The following is a description of a gene set: NR1H2 and NR1H3-mediated signaling Human Gene Set: REACTOME_NR1H2_AND_NR1H3_MEDIATED_SIGNALING studied in species Homo sapiens, and this is the list of marker genes: APOD, FASN, SCD, MYLIP, TNRC6A, EP300, TBL1X, NRIP1, ABCA1, EEPD1, APOC1, MOV10, TNRC6B, KDM1B (NCBI Gene Id 254751), RXRA, APOC4, KDM4A, PLIN1 (perilipin 1), ANGPTL3, AGO1, TBL1XR1, RXRB, NR1H2, NCOA1, NCOR2, APOC2, APOE, ABCG1, GPS2, ARL4C, AGO2, NCOR1, KDM3A, AGO4, NR1H3, UGT1A3, KDM1A, PLTP, PCK1, FABP6, SREBF1, ABCG8, ABCG5, HDAC3, CETP, TNRC6C (NCBI Gene Id 57690), AGO3